Given this list of marker genes Onecut3, Riox2, Csn1s1, Ceacam12, St3gal1, Phox2b, Nif3l1, Pnrc1, Atf2, Fbxo42, Zfp958, Map1lc3b, Tbr1 (NCBI Gene Id 21375), Rnf157, Marveld1, Cdh12, Tmem30b, Tstd2, B3gat3 (NCBI Gene Id 72727), Adcyap1, Nlk, Usp1, Dyrk1a, Cacna1b, Ttc21b (tetratricopeptide repeat domain 21B), Cyp27b1, Luc7l3, Nrxn1, Exoc6b, Adrb3, Tbl1xr1, Dcaf5, Pbxip1, Brd1 (bromodomain containing 1), Ulk2, Etl4, Tyw3, Tmem207, Nanos1, Kif2a, Rmnd5a, Kcnc2, Smad4, Kcnab1, Cnst, Abi1, Rora, Cpne4, Klf6, Apol7a, Slc44a3, Yipf3, Synj2, Chd6, Dock4, Ankrd13b, Adam10, Hoxc6, Asxl2, Fbxo30, Dscaml1, Sucla2, S1pr3, here is a description of the gene set: from publication Chen Y, Wang X (PMID 31504780) Genes predicted to be targets of miRBase v22 microRNA mmu_miR_7005_3p in miRDB v6.0 with MirTarget v4 prediction scores > 80 (high confidence targets). species: Mus musculus Mouse Gene Set: MIR_7005_3P